The following is a description of a gene set: species: Mus musculus Mouse Gene Set: MIR_6923_5P Genes predicted to be targets of miRBase v22 microRNA mmu_miR_6923_5p in miRDB v6.0 with MirTarget v4 prediction scores > 80 (high confidence targets). from publication Chen Y, Wang X (PMID 31504780), and this is the list of marker genes: Agbl3, Zfp446, Mtfr1l, Kcnn4, Sumo1, Zfp93, Wdr82, Mboat2 (NCBI Gene Id 67216), Rapgefl1, Egln1, Abca9, Ankfy1, Sfrp2, Myh10, Dok4, S100a10, Casd1, Tyms, Zfp867, Ccar2, Pcbp2, Mbnl3, Rab21, Pou2af3, Nhs, Sh3gl2, Stab1, Zdhhc8, Ndel1, Pcp4l1, Cramp1, Pgghg, Gadd45a, Zfp429, Brinp2, Azgp1, Tmem221, Cst6, Pde4dip, Pdik1l, Morc2a, Peg10, Cwf19l1, Pa2g4, Zfp169, 4930480E11Rik (RIKEN cDNA 4930480E11 gene)